The following is a description of a gene set: Human Gene Set: GOBP_VIRAL_GENE_EXPRESSION A process by which a viral gene is converted into a mature gene product or products (proteins or RNA). This includes viral transcription, processing to produce a mature RNA product, and viral translation. species: Homo sapiens, and this is the list of marker genes: TRIM11, BRD4, DENR, NUCKS1, SPCS1, TAF11, ST3GAL1 (NCBI Gene Id 6482), MOGS, TRIM8, MGAT4C, PARP10, TMPRSS2, GTF2B, DHX9, MAN1B1, MGAT1, SSB, MCTS1, HMGA2, TRIM32, CCNT2, CHD1, TARBP2, JUN, EDEM2, TRIM31, ATG12, TRIM27, FUT8, ST3GAL2, RRP1B, USF1, PRMT1, ST6GAL1, PEG10, ZNF639, HPN, PSMC3, SNW1, SP100, FURIN, RSF1 (remodeling and spacing factor 1), CCL4, ST3GAL3, OAZ3, CDK9, GSK3B, HDAC1, LEF1, ST6GALNAC4, SPCS3, ZFP36, SMARCA4, TRIM13, EIF3B, MON1B, REST, IFIT1, MGAT2, PARP9, CCNT1, IFITM3, PARP16, ATG5, EIF2D, LARP7, UBP1, ST6GALNAC2, MID2, USF2, EIF3A, PTBP1, TRIM21, HEXIM1, MAN2A1, EIF3G, EIF3L, OAZ2, TRIM62, CANX (NCBI Gene Id 821), INPP5K, MGAT4B, POU2F3, EIF3F, TARDBP, MGAT5, SHFL, SMARCB1, CSNK1A1, CCL3, EIF3D, TRIM14, GSK3A, TFAP4, GALNT1 (polypeptide N-acetylgalactosaminyltransferase 1), ST3GAL4, EP300, ATP7B, MGAT4A, OAZ1, CCL5, PCBP2, EIF2AK4, MDFIC, ST6GALNAC3, CSDE1, CTDP1, SP1, ACE2